The following is a description of a gene set: species: Homo sapiens from publication Chen Y, Wang X (PMID 31504780) Human Gene Set: MIR324_5P Genes predicted to be targets of miRBase v22 microRNA hsa-miR-324-5p in miRDB v6.0 with MirTarget v4 prediction scores > 80 (high confidence targets)., and this is the list of marker genes: AP1G1, SP1, ABRAXAS2, KLF7, PIGM, CMTM4, RAN, TMCC1, TMEM135, MAP4K3, SEPTIN3, ERLIN2, ZFP91, DGKH, ZNF197, PBX1, RBFOX2, PCYT1B, RACGAP1, TAFA2, MGAT3, PRKCG, HFE (homeostatic iron regulator), EGR2, BUB1 (NCBI Gene Id 699), CDS1, VDAC1, CAMKV, UBE2I, HOXA2, ELAVL1, SLC19A3, RBL1, ZNF713 (zinc finger protein 713), FAM237A, GAN, ENSA, CPT1A, ATXN7, CRISP1, CAMK2G, KCTD20, KLF3, MYO7A